The following is a description of a gene set: Mouse Gene Set: MP_DECREASED_TUMOR_NECROSIS_FACTOR_SECRETION from publication Motenko H, Neuhauser SB, O'Keefe M, Richardson JE (PMID 26092688) species: Mus musculus Mouse genes annotated to decreased tumor necrosis factor secretion (MP:0008561) retrieved from the Mouse Genome Informatics database via MouseMine, and this is the list of marker genes: Nod2, Tril, Nme2, Il25, Sh3bp2, Ccr4, Nfkb1, Azi2, Selenok, Retnlb, Ifit2, Pigr, Ifnar1, Slc15a4, Mmp7, Klhl22, Peli1, Syk, Clec4e, Sash3, Apba3, Gimap5, Lta, Tnf (tumor necrosis factor), Cul5, Siglec1, Cr2, Sh3yl1, Tlr4, Fcmr, Cnpy3, Il1b, Clec4n, Cd1d1, Fastk, Tlr3, Ccdc88b, Ticam2, Ikbkg, Mavs (NCBI Gene Id 228607), Mir155, Cd36, Adora3, Tlr1, Irak2, Pi4ka, Tarm1, Il18, Ly96, Usp20, Ccar2, Dhx58, Traf6, Il1r1, Coro1a, Plcg2, Mapkapk2, Ccr1, Tirap, Pla2g2d, Abhd16a, Hcfc2, Cd14, Ido2 (NCBI Gene Id 209176), Ifngr2, Lgmn, Pla2g4a (NCBI Gene Id 226493), Tlr2, Gpr65, Nfkbib, Nfatc2, Klrc1, Nod1, Cxcl5, Rasgrf2, Ifnb1, Map3k8 (mitogen-activated protein kinase kinase kinase 8), Clic4, Ifngr1, Nfe2l2, Myo1g, Sgms1, Fads1, Tollip, Tlr9, Ticam1, Unc93b1, Myd88, Stim1, Itgax, Cd19 (NCBI Gene Id 12478), Ifi204, H2-Ab1, Trim8, Mir378b, Card9, Tnfsf14, Prkce, Hif1a, Gpr108, Ripk2 (receptor (TNFRSF)-interacting serine-threonine kinase 2), Rhbdf2, Dlg1, Thbd, Tnfrsf14, Vav1, Fcer1g, Tlr7, Timd4, Ccr6, Lbp, Marchf1, Spp1, Pycard, Nox4 (NCBI Gene Id 50490), Mtor, Cd69, Clec7a, Irak4, Irf5, Hmox1, Pde4b, Elane, Ffar2, Pilrb1, Tlr6, Clec4d